The following is a description of a gene set: studied in species Homo sapiens Enables the transfer of a single solute from one side of a membrane to the other by a mechanism involving conformational change, either by facilitated diffusion or in a membrane potential dependent process if the solute is charged. Human Gene Set: GOMF_PASSIVE_TRANSMEMBRANE_TRANSPORTER_ACTIVITY, and this is the list of marker genes: CACNB4, P2RX7, TRPV3, CACNG2, AQP8, HTR3C, KCNG2, PHPT1, GABRR3, RACK1, TOMM40L, KCNK16, PANX3, CACNA1I, MCOLN2, LRRC8B (leucine rich repeat containing 8 VRAC subunit B), CABP4, GPR89B, TMC1, MICU3, SLC17A8, CABP5, TRPV6, PIEZO2, KCNA1, CACNB3, KCNMB4, TMEM266, NALF1, SCN5A, GABRG3, CACHD1, CACNA1S, ANO1, KCNMB2 (potassium calcium-activated channel subfamily M regulatory beta subunit 2), ZACN, TMEM63A, SLC24A4, AMBP, GJA3, CACNA1F, ATP5F1EP2, P2RX1, VAMP8, SLC12A5, KCND1, CLIC4, TMCO1, KCNN2, AQP12B, TMPRSS3, KCNK4, RHBG, TTYH1, BCL2A1, GHITM, ATP5F1C, SCN2A, GJC2, FGF12, CACNG7, NPY, AQP4, TMEM168, GRIN1, GRIN3B, SLC26A6, SLC24A5, CLCN4, KCNH7, LRRC8C, GABRB2, CACNA1G, SHOC2 (NCBI Gene Id 8036), KCNG1, GPLD1, TMEM175, BCL2L10, ATP2A2, BEST3, KCNK10, CLIC5, TRPM5, CHP1, CLCA4, RRAD, CHRNE, KCNJ15, ANO2, TMEM37, GSTM2, SCNN1D, KCNK17, SCN8A, ABCC8, CYBB, TRPM8, CALHM1, SCLT1, MCUB, KCNC3, MICU2, FXYD6, SGK2, SCN2B, ASIC3, TRPC1, KCNB1, SLC24A2, SLC1A7, PDE4B, WNK4, BEST4, DPP6, CRISP1, LRRC38, KCNJ14, GJB5, P2RX5, CACNA2D1, GRIN2B, CNIH3, GRIA4, SNAP25, CAV1, ANK3, CHRNA6, TMEM109, KCNAB3, NOX5, ATP5F1A, CLCA2, GJC3, SCN10A, NALF2 (NCBI Gene Id 27112), SMDT1, ANXA6, STING1 (NCBI Gene Id 340061), CAMK2D, GJC1, BAX, SCN1A, ATP2B4, SRI, CHRFAM7A, KCNK5, CLCN1, KCNU1, CACNG1, KCNA10, SCNN1G, ANO4, ANO8, CLIC6, KCNQ3, GABRB3, GRIN2D, CHRNA4, GABRB1, GABRA4, GPR89A, PACC1, FXYD2, KCNQ1, ATP5F1E, STIM1, SLC14A1, P2RX4, APOL1, REM2, CACNA2D2, BOK, DLG1, FKBP1B, CLIC1, ASIC2, AKAP9, SLC24A1, BEST2, TMC5, ATP5F1B, HTR3D, FGF11 (NCBI Gene Id 2256), ANO9, CATSPER2, CNGA3, STX7, GRIA3, MT-ATP6, SNTA1, CACNA1H, PKD2, TMEM120A, GABRA6, PIEZO1, CACNA1C, RYR3, ATP5F1D, CALHM6, KCNE1, ADRB2, CABP2, PKD1L3, KCNJ18, ATP5PD, TMC6, GJB1, GRID2, TPCN1, KCNH6, TRPC3, YWHAH, TSPOAP1, FGF13, CLCN7, CHRND, NPY2R, GABRA5, ANO10, KCNQ5, GLRB, ATP5PO, GJD3, FKBP1A, NRXN1, KCNQ2, KCNA3, KCNIP1 (NCBI Gene Id 442143), YWHAE, OPRM1, KCNK6, ITPR2, SCN4B, PKDREJ, MPEG1, GJB7, CNGB3, HTR3A, GABRP, CALHM2, MPV17, GRIN3A, ATP5MF, TRPV5 (NCBI Gene Id 56302), OTOP3, CLCN3, TRPV1, DPP10, NALCN, GJB6, TMEM63B, CHRNB3, SLC12A2, COMMD1, KCNAB2, AQP3, PKD2L2, KCNJ8, AQP12A, FXYD1, CLCN6, ANK2, TMEM38A, KCNK18, HVCN1, KCNC4, NOS1, HCN1, AQP9, KCNJ13, CHRNB2, OTOP2, CALM1, ATP2A3, AQP7, GABRD, KCNJ1, AMIGO1, HCN2, CLDN4, DRD4, PKD1, KCNK3, KCNN4 (potassium calcium-activated channel subfamily N member 4), GJE1, TTYH3, GABRG2, KCNJ6, CHRNA3, CALM3, TMEM120B, LRRC55, KCNH5, GLRA3, KCNJ10, KCNE5, HTR3B, GRIA1, SLC17A7, TRPC4AP, SCN3A, KCNJ16, BEST1, SLC5A3, KCNF1, RHD, ITPR1, SLC6A4, CHRNA1, ANO5, AGT, CABP1, KCNA5, CACNG4, OCA2, MFSD8, KCNMA1, ANO7, WWP2, SCNN1B, GJA4, AQP10, KCNIP4, STOM, MIP, CLIC3, RYR1, CACNG5, GJA9, LRRC26, CACNA2D3, TRPA1, KCNH3, RASA3, GRID1, ACTN2, ORAI1, GABRR2, KCNQ4, TMC4, ATP5MC1, GRIN2A, PCSK9, STIMATE, SLC17A3, GJD2, SCN4A, CLCNKA, CNGA4, P2RX6, PACSIN3, PKP2, KCNA4, SLC30A1, GJB3, CATSPER1, CHRNA2, NHERF1, CACNA1E, SLC24A3 (NCBI Gene Id 96617), TPTE, KCND2, SLC1A4 (NCBI Gene Id 6509), CALHM3, TPTE2, MT-ATP8, GABRR1, KCNK15, FHL1, LRRC52 (NCBI Gene Id 440699), KCNE2, HCN3, CNGA2, FLNA, KCNA7, KCNH2, KCNJ2, KCNV2, GABRA3, FXYD6P3, SLC9C1, FXYD4, TRPM2, BCL2L2, CLCA1, AQP7B, KCNA2, PANX1, SCN7A, FXYD3, ITGAV, TMC7, SCN9A, CUL5, KCNK2, FGF14, LAMP1, TMEM87A, TMEM63C, GEM, LYNX1, CHRNG, OXSR1, VTI1B, GLRA1, VDAC1, CATSPER4, TMC8, TMEM38B (NCBI Gene Id 55151), NRXN2, ATP5MGL, SCN1B, CACNA2D4, FXYD7, TRPV2, AQP1, ORAI2, TRPM3, PRKG1, AQP2, TTYH2, KCNS2, NCS1, ENSA, GRIK4, GRIK1, GJA1, LRRC8E, STIM2, CNGA1, SLC4A11, GJD4, KCNT1, KCNH1, GRIA2, TPCN2, ITPR3, ATP5MG, TRPC6, TRPM7, PKD1L2, ANO6, PRKACA, ANKRD36C, PTPN3, GABRQ, AQP5, KCNN1, LRRC8D, CHRNA5, TMC2, ASIC5, SLC1A1, NEDD4L, GJB2, ATP5ME, KCNH8, GSDMB, CAV3, KCNMB3, RASA1, SGK1 (serum/glucocorticoid regulated kinase 1), ATP5PB, GLRX, RSC1A1, REM1, TRPC4, KCNK1, KCNN3, KCNA6, KCNS3, SLC26A7, CHRNA10, KCNMB1, GABRE, GSDME, GRM2, GRIN2C, GRM3, SLC26A9, RHCE, AQP11, PANX2, CLIC2, GPD1L, GJA5, RANGRF, CACNA1D, GPM6A, LAMP2, ARPP19, P2RX2, GABRA2, UNC80, CACNG6, CACNB2, CLCN5, TMC3, KCNS1, MCL1, CCT8L2, PSEN1, ASIC1, KCNJ5, MICU1, KCNK9, GSDMA, KCNG3, PDE4D, BNIP1, AQP6, KCNJ11, GRINA, CFTR (CF transmembrane conductance regulator), KCNH4, GJB4, SLC26A11, CALM2, SUMO1, TRPM1, TRPC5, GSDMC, BAK1, CLDN17, KCNG4, CALHM4, KCNE4, TRPM6, GRIK5, PRF1, GRIK3, CACNG3, SHROOM2, AKT1, SLC1A5, GJA10, CATSPER3, FAIM2 (NCBI Gene Id 26294), ANO3, SCN11A, CLCC1, CACNB1, KCND3, TNNI3, PDPN, KCNC2, SCN3B, TRPV4, GABRA1, GJA8, KCNK7, TMBIM4 (NCBI Gene Id 51643), P2RX3, ATP5PF, PRKCB, STX1A, HPCAL4, STK39, SNF8, CLCN2, CACNA1A, ATP6V0C, CHRNA9, CHRNA7 (cholinergic receptor nicotinic alpha 7 subunit), TSPAN13, ASIC4, SLC26A8, HTR3E, NMUR2, KCNT2, KCNAB1, TMBIM6 (NCBI Gene Id 7009), RHAG, LRRC8A, SEC61A1, KCNE3, BSND, ORAI3, KCNC1, MCOLN3, RHCG, FXYD5 (NCBI Gene Id 53827), CACNA1B, TMBIM1, TMEM150C, PKD2L1, MCOLN1, KCNIP2, DCD, BCL2L1, RYR2, KCNJ4, KCNK13, NHERF4, KCNK12, VDAC3, HCN4, SLC17A6, MCU, SCNN1A, OTOP1, BCL2, GRIK2, KCNJ9, ABCC9, SLC5A8, TRPM4, GABRG1, KCNV1, SGK3, GSDMD, KCNJ3, TRPC7, KCNIP3, PKD1L1, CHRNB4, CACNG8, VDAC2, KCNB2, CNGB1, C8orf44-SGK3, KCNJ12, NEDD4, CHRNB1, TOMM40, CCDC51, STX8, CLCNKB, CALHM5, DRD2, GLRA2